Given this list of marker genes Slc1a3, Aldh1a1, Gad2, Aldh5a1, Slc38a1, Abat, Gad1, Phgdh, here is a description of the gene set: Mouse Gene Set: GOBP_GAMMA_AMINOBUTYRIC_ACID_METABOLIC_PROCESS species: Mus musculus The chemical reactions and pathways involving gamma-aminobutyric acid (GABA, 4-aminobutyrate), an amino acid which acts as a neurotransmitter in some organisms.